The following is a description of a gene set: studied in species Homo sapiens Human Gene Set: WP_MFAP5_EFFECT_ON_PERMEABILITY_AND_MOTILITY_OF_ENDOTHELIAL_CELLS_VIA_CYTOSKELETON_REARRANGEMENT MFAP5 effect on permeability and motility of endothelial cells via cytoskeleton rearrangement, and this is the list of marker genes: MYLK, ITGB3, PXN, PLCG1, JUN, MAPK3, MYL2, ITPR1, ITGAV, CREB1, MAPK1, VCL, ACTN1, TJP1, MFAP5, LPP, PTK2, PRKCQ (protein kinase C theta)